The following is a description of a gene set: Table S2: Representative genes of each cell cluster Mouse Gene Set: ZHANG_UTERUS_C3_PROLIFERATIVE_STROMAL1_STROCXCL14_HIGH_CELL from publication Zhang L, Long W, Xu W, Chen X, Zhao X, Wu B (PMID 35669188) species: Mus musculus, and this is the list of marker genes: Rpl11, Malat1, Rps27l, mt-Nd1 (mitochondrially encoded NADH dehydrogenase 1), Rnase4, Ctla2a, Hoxa10, Igfbp4, Cxcl14, Mmp14, Mylk, Myl9 (myosin, light polypeptide 9, regulatory), Fn1, Igfbp7, Rarres2, Lsp1, Rpl18, Tsc22d1, Osr2, Mfap2, Rpl39, Aprt, Cox6c, Gpx3, Ptms, Plac8, Cox7c, Nupr1, mt-Nd4, Sox4, mt-Rnr1, Nbl1, Npc2, Cdk4, Zbtb20, Rpl30, Rpl26, Cox4i1, Rbp1, B2m, Rps27, Cnpy2, Id3, mt-Cytb, Rps26, Rps21, Mmp2, Rpl34, Cpe, Sparcl1, Cfh, Pltp, Mif, Ndufb9, Ptma, Chchd10, Hes1 (hes family bHLH transcription factor 1), Timp2, mt-Nd2, Tmem256 (NCBI Gene Id 73085), Dio2, Cox6b1 (NCBI Gene Id 66542), Mmp11, Actb, Marcks, Mdk, Lgals1, Rpl38, Rps28, Micos10, Tpt1, Ctsl, Cdkn1c, Cmtm3, Rplp1, Rps17, mt-Rnr2, Cd63